The following is a description of a gene set: The attachment of a cell to a second cell of the identical type via adhesion molecules. Mouse Gene Set: GOBP_HOMOTYPIC_CELL_CELL_ADHESION studied in species Mus musculus, and this is the list of marker genes: F2rl3, Il6, Alox12, Tspan32, Sh2b3, Dsp, Ctsg, C1qtnf1, Gm1123, Vps33b, Mmrn1, Map2k1, P2ry12, Gnas, Stxbp1, Plaur, Fgb, Ptpn6, Lyn, L1cam, Gata1, Pdia3, Ubash3b, Il6ra, Bloc1s4, Jak1, Fga, Gp6, Dsc2, Stxbp3, Pip5k1c, Prkcq, Ncam1, Comp, Ank3, Cdhr2, Cdhr5, Ubash3a, Itgb3, Emilin1, Pdpn, Wnt3a, Mip, Ccl5, F11r (F11 receptor), Emilin2, Ppia, Pear1, Pdgfra, Cxadr, Pdia4, Tubb1, Tnfsf11, Lgals1, Cfh, Megf11, Serpine2, Adamts18, Prkg1, Plpp3, Plek, Cd24a, Slc6a4, Rap2b, Pdia2, Htr2a, Ptpru, Tspan9, Prkcd, Entpd1, Syk, Gla, Tmx1, Ctnna3, Mfsd2b, Prkca, Fermt3, Jak2, Ccm2l, Cela2a, Megf10, Rdx, Ceacam1, Pdia6, Pkp2, Zfp703, Fgg, Tyro3, Jup, Cd9, Dsg2, Tjp2, Slc7a11